The following is a description of a gene set: species: Mus musculus Mouse Gene Set: GOBP_MODULATION_OF_INHIBITORY_POSTSYNAPTIC_POTENTIAL Any process that modulates the frequency, rate or extent of inhibitory postsynaptic potential (IPSP). IPSP is a temporary decrease in postsynaptic membrane potential due to the flow of negatively charged ions into the postsynaptic cell. The flow of ions that causes an IPSP is an inhibitory postsynaptic current (IPSC) and makes it more difficult for the neuron to fire an action potential., and this is the list of marker genes: Rims1, Rims2, Igsf9b, Chrna2, Grin2b, Abat (NCBI Gene Id 57428), Nlgn3, Grin2a, Dbn1, Drd4, Unc13b, Ntsr1, Nlgn2